Given this list of marker genes Cfl1 (NCBI Gene Id 12631), Hrg, Slit2, Abi3, Plxnb3, here is a description of the gene set: Mouse Gene Set: GOBP_NEGATIVE_REGULATION_OF_LAMELLIPODIUM_ASSEMBLY Any process that decreases the rate, frequency or extent of the formation of a lamellipodium, a thin sheetlike extension of the surface of a migrating cell. species: Mus musculus